The following is a description of a gene set: Human Gene Set: HP_ABNORMAL_3RD_FINGER_PHALANX_MORPHOLOGY studied in species Homo sapiens Abnormal 3rd finger phalanx morphology Abnormality of the phalanges of the 3rd (middle) finger., and this is the list of marker genes: GNAS, COL2A1, FGFR2, TWIST1, NSDHL, GDF5, CHSY1